The following is a description of a gene set: studied in species Mus musculus Mouse Gene Set: GOBP_PROTON_TRANSPORTING_TWO_SECTOR_ATPASE_COMPLEX_ASSEMBLY The aggregation, arrangement and bonding together of a proton-transporting two-sector ATPase complex, a large protein complex that catalyzes the synthesis or hydrolysis of ATP by a rotational mechanism, coupled to the transport of protons across a membrane., and this is the list of marker genes: Tmem9, Atpaf1, Pip4p1, Atp6ap1, Tm9sf4, Vma21, Tmem242, Oxa1l (oxidase assembly 1-like), Atp6v1b1, Fmc1, Atp23, Atpaf2, Aldob, Tmem199, Atp5f1d, Ccdc115, Tmem70